The following is a description of a gene set: Human Gene Set: GOBP_SKELETAL_MUSCLE_CONTRACTION A process in which force is generated within skeletal muscle tissue, resulting in a change in muscle geometry. Force generation involves a chemo-mechanical energy conversion step that is carried out by the actin/myosin complex activity, which generates force through ATP hydrolysis. In the skeletal muscle, the muscle contraction takes advantage of an ordered sarcomeric structure and in most cases it is under voluntary control. species: Homo sapiens, and this is the list of marker genes: SYNM, ATP2A1, HOMER1, GSTM2, EEF2, C12orf57, ACTN3, TCAP, GAA, TNNI1, MYH7, ATP8A2, DMPK, JSRP1, CHUK, DMD, GSTO1, STAC3, ADGRD1, CAV3, CHRNA1, MYH3, CCDC78, TTN, TNNI2, PVALEF, SCN4A, MYH8, CHRNB1, DDIT3, STAC2, CASQ1, KBTBD13, RCSD1, TNNT3, TNNI3, REM1, MYH14, HSP90AA1, TNNT1, STAC, TNNC2, TNNC1, PRKD1, KCNJ2, SLC8A3, FKBP1A, TNF, CHRND, STRIT1, SELENON